The following is a description of a gene set: The aim of this study was to identify genes regulated by IL-12, IL-18 and IFN-alpha during early differentiation of human Th1 cells Genes down-regulated in the activated CD4 T cells (48h): IL-12 versus interferon alpha. species: Homo sapiens from publication Filén S, Ylikoski E, Tripathi S, West A, Björkman M, Nyström J, Ahlfors H, Coffey E, Rao KV, Rasool O, Lahesmaa R (PMID 20304822) Human Gene Set: GSE20198_IL12_VS_IFNA_TREATED_ACT_CD4_TCELL_DN, and this is the list of marker genes: HGSNAT, ARSB, GABARAPL1, SPATA33, ACAA2, ADCY7, TCIRG1, VAT1, MFSD2A, RCOR3, TUBB3, MMP8, KRT80, NUCB1, TMEM132C, HM13, TBL1X, DYNC2I2, SDR39U1, JADE1, TNFRSF1A, SSX2IP, FBXO45, PARN, PYCR2 (NCBI Gene Id 29920), TMEM51, CGAS, RAI1, PITPNM1, ARFGEF1, GID4, CDK1, DRG1, ACOD1, DHX32, TRIM35, CFAP418, PDIK1L, LPGAT1, AP3B1, ATG13, UXS1, UBQLN2, FBXW8, CHIC2, MAN2A1, CD200R1L, TIAM1, ZBTB20, ATXN1L, CCDC112, FAM229A, NCOA1, CLCF1, KDM5B, SACM1L, MAP3K5, LSP1, PSMC2, MYL3, STRIP1, ADNP, FBXO3, SETD1A, TECPR1, SCYL2, NUP214, CCNE2, PTPN12, TP63, MTOR, CD82, SEPTIN6, NAB2, SVIL, AAK1, GRHL1, ACSBG2, IGBP1, RFNG, GPR180, CSF2RA, RPS6, PLEKHM1, ZNF32, LIMK2, CBLB, RASGEF1A (NCBI Gene Id 221002), CMIP, PHKA2, ITGB2, MAP1LC3B, NUDT16, BRIP1, MSS51, TDRD7, TPRA1, KMT2E, LIMD2, EXTL3, MSN, GPR137B, KRTAP2-4, UBQLN1, IZUMO4, PINK1, PHF3, FHOD1, SLC25A24, TSHZ1, CEP131, ZNF236, HEPACAM2, DNAH8, TRARG1, VPS37C, UBE2N, FDFT1, KAT6A, HEPACAM, HLTF (helicase like transcription factor), NCKIPSD, DCUN1D1, SKP1, TNIK, THAP7, MTMR9, TTLL11, SYT1, CACNA2D2, DDHD1, AFG1L, VPS41, ARID1A, GDPD3, CPXM2, NCK2, ICMT, PTBP3, ST8SIA4, H2BC5, DDX42, LIPA, SESN3, SNAPC2, E2F8, ZNF354C, TLK2 (NCBI Gene Id 11011), ATRX, TMEM165, VOPP1, ZNF282, KEAP1, ATXN7L3, SLAIN2, PLK2, ZFP30, MCAT, FBXO25, MAP3K3, LRRC8D, PTPN20, DDRGK1, PRNP, NADK, GPR25, PHF1, DGKZ, EPM2AIP1, SRRT, PLCXD1, KIFAP3, METTL15, RIF1, VAPB (NCBI Gene Id 9217), SASS6, VPS36, ZMIZ1, GSK3A, C11orf24, ACADVL, TXN, TRAPPC6A, RSAD2, RHAG, EID1, CDC25B, CELSR3, ABCC5, BCL6, PPP2R5D, CECR2, RETREG3, GOT2, CALR, APOE, NEFH, NUDCD2, NOP2